Given this list of marker genes TIMP2 (TIMP metallopeptidase inhibitor 2), MGP, COL15A1, VIT, SPON2, C1S, JUND, DHRS7, MFAP4, FN1, SERPINF1, LUM (NCBI Gene Id 4060), IGFBP7, MXRA8, CXCL14, ITM2B (integral membrane protein 2B), EMP3, MT-ND3, NDFIP1, FBLN2, FMO2, GPNMB, FCGRT, ATP5MC1, LHFPL6, CFH, ACKR3 (atypical chemokine receptor 3), SELENOP, LTBP4, TRAM1, SELENOS, DPT, S100A13, PSAP, ADH1B, S100A4, ARL6IP5, C3, NFE2L2, RND3, COL6A1, DDAH2, PCOLCE, RBPJ, MME, CSTB, CPQ, FBLN1, MAP1B, HSD11B1, PDGFRA, CHD9, AKR1B1, ABCA8, MYOC, PI16, CFD, LGALS3BP, APP, TSPAN4 (tetraspanin 4), HSPA5, IGF1, VIM, COL1A1, PLAC9, FGL2, AP3S1, NFIA, ANXA2, CYB5A, SSPN, PTGDS, HSP90B1, FSTL1, SELENOM, SMOC2, RAB1A, GPX4, FBLN5, EFEMP1 (NCBI Gene Id 399564), DBI, NR3C1, ABCA10, CD63, LAMC1, RTN4, NPC2, LAPTM4A, PDIA3, LMNA, CILP, CYB5R3, MGST1, MEG3, MMP2, SSR4, PRDX1, COL1A2, C1R, ANGPTL1, ALDH1A1, HTRA3, KDELR2, ATP6V0E1, PDGFRL, CYBRD1, REEP5, CD81, SRI, APOD, RAB2A, DAB2, SLC66A3, VCAN, NOVA1, LIMA1, IGFBP6, GSN, TMCO1, COL3A1, CCN5, CKS1B, ARF4, CST3, S100A11, CHRDL1 (NCBI Gene Id 91851), AKAP12, CXCL12, DCN, ATP6AP2, NUPR1 (nuclear protein 1, transcriptional regulator), S100A6, FHL1, SFRP4, TMEM59, LSP1, CD99, SERPING1, SSR2, TMED2, EPHX1, LRP1, EID1, PGF, TIMP1, TNXB, SDC2, ADD3, PRDX4, ISLR, SGCE (NCBI Gene Id 8910), PODN, LAMA2, TMEM14C, S100A10, HSPG2, MALAT1, GPX3, TCEAL9, PPIB, KRTCAP2, MARCKS, COL6A3, EMP1, PMP22, NDUFS4, FXYD1, ATRAID, BEX3, ABCA9, TFPI, MFAP5, COL6A2, ANXA1, PLPP3, SPRY1, TSC22D3, SCN7A, CCDC80, here is a description of the gene set: Human Gene Set: RUBENSTEIN_SKELETAL_MUSCLE_FAP_CELLS from publication Rubenstein AB, Smith GR, Raue U, Begue G, Minchev K, Ruf-Zamojski F, Nair VD, Wang X, Zhou L, Zaslavsky E, Trappe TA, Trappe S, Sealfon SC (PMID 31937892) species: Homo sapiens